Given this list of marker genes PTPN12, HIP1, MYOCD, LRP1, LOX, PTPN2, SRC, HIP1R, here is a description of the gene set: Human Gene Set: GOBP_REGULATION_OF_PLATELET_DERIVED_GROWTH_FACTOR_RECEPTOR_BETA_SIGNALING_PATHWAY studied in species Homo sapiens Any process that modulates the frequency, rate or extent of platelet-derived growth factor receptor-beta signaling pathway.